The following is a description of a gene set: electronically inferred by orthology from the curated human pathway This event has been computationally inferred from an event that has been demonstrated in another species.<p>The inference is based on the homology mapping from PANTHER. Briefly, reactions for which all involved PhysicalEntities (in input, output and catalyst) have a mapped orthologue/paralogue (for complexes at least 75% of components must have a mapping) are inferred to the other species. part of: Cardiac conduction species: Mus musculus Reactome Pathway: Ion homeostasis, and this is the list of marker genes: Prkaca, Tnni3, Fxyd3, Trpc1, Camk2b, Pln, Casq1, Atp1b2, Atp1b1, Atp2a1, Fkbp1b, Fxyd2, Trdn, Atp1b3, Atp2b1, Stim1, Atp2b3, Atp1a3, Calm1, Atp2b4, Ryr1, Kcnj11, Atp1a2, Atp2a3, Dmpk